Given this list of marker genes BMP2, WNT4, PDE8B (NCBI Gene Id 8622), DKK3, ATP1A1, BMP5, REST, here is a description of the gene set: Any process that stops, prevents, or reduces the frequency, rate or extent of the chemical reactions and pathways resulting in the formation of hormones. studied in species Homo sapiens Human Gene Set: GOBP_NEGATIVE_REGULATION_OF_HORMONE_BIOSYNTHETIC_PROCESS